Given this list of marker genes BAZ2A, GMFG, VPS54, NEMF, PRR14, KCTD12, PKP3, SEC63, GRAMD2B, LIPA, CMAS, UTP25, SLA2 (NCBI Gene Id 84174), SCAMP3, SCML4, GMFB, SEC23B, UBAC2, DPH5, DOCK2, INPP1, RPS6KB2, UBE2H, LAMTOR3, HECTD3, SNX10, SLC2A4RG, HELZ2, EVI2B, CD164, IRAK3 (NCBI Gene Id 11213), UNC5A, IRF2, EMG1, FAM53A, SSBP4, RUNDC1, PHAF1, ALKBH1, TWF2, TMOD3, JAK3, TRAPPC8, TRAM1, GIMAP4, EGR1, GRB2, ESYT1, LMBRD1, FERRY3, DBNL, TSR1, TAB2, SMAD7, MFNG, PCMTD2, AKAP8, METRNL, MTERF3, CXXC1, DPP4, CFAP141, RER1, ZYG11B, ITGA6, DUSP11, SLC15A4, PREB, SELL, RBFA, SLC35G1, USP12, RCN1, TAF8, IFT57, ACP5, PRKD3, EIF2AK1, NCLN, UBE2F, CLK4, DGKA, AGER, NDUFAF4, POU2AF1, NFKBIE, HBP1 (HMG-box transcription factor 1), ADGRA3, NFRKB, FEZ2, C14orf119, RIMOC1, SNX14, C18orf32, RAB19, SQOR, PON2, KLHDC3, RFK, CIB1, RC3H1, RHOBTB2, WDR43, MTLN, PFN1, PAPOLG, STING1, MCTP2, ATF7IP, RNASET2, OSTM1, TYROBP (transmembrane immune signaling adaptor TYROBP), ZNF260, UPF2, CISD1, ACADL, ATP10A, BCCIP, TMEM126A, YWHAZ, SLC9A9, ITGB3, TASP1, SLC25A33, RPS6KA1, PTPRE, PLCG2, GIMAP8, NARF, TENT4B, L1CAM, GDI1, ATP6V0A2, STIM2, CALCRL, SLC36A1, RSRC2 (NCBI Gene Id 65117), PHLPP1, PLOD1, BACH1, EHD3 (EH domain containing 3), UBALD2, AKIRIN1, ARHGAP1, PLCXD2, IL18RAP, SAMHD1, EEIG1, ITGB1BP1, DCAF11, SNRK, CREB3, SLAMF6, ANKRD11, RAB5IF, S1PR4, UQCRHL, ZFC3H1, LBH, PRR14L (NCBI Gene Id 84194), NDUFA6, ABCF2, PRKAR2A, C5orf34, SEC16A, ANKIB1, ENSA, HSD17B4 (NCBI Gene Id 3295), MYO6, PATZ1, RBM33, DMTF1, SEPTIN9, RBX1, SNAP23, TRPM4, MARCHF2, PNN, SRSF6, SYS1, SH2D1A, DCAF8, CYB5A, SIRT2, SIDT2, YTHDC1, CNP, ZDHHC3 (zinc finger DHHC-type palmitoyltransferase 3), SLCO4A1, SENP7, STX16, GBP7, GDAP2, SLA, SELENOO, FAM32A, BBLN, GATD3, ITPKB, SNX33 (NCBI Gene Id 257364), here is a description of the gene set: from publication Dik WA, Pike-Overzet K, Weerkamp F, de Ridder D, de Haas EF, Baert MR, van der Spek P, Koster EE, Reinders MJ, van Dongen JJ, Langerak AW, Staal FJ (PMID 15928199) studied in species Homo sapiens T cells develop from progenitors that migrate from the bone marrow into the thymus. Thymocytes are subdivided roughly as being double negative (DN), double positive (DP), or single positive (SP), based on the expression of the CD4 and CD8 coreceptors. The DN stage is heterogeneous and can be subdivided into four distinct subsets in mice based on the expression of CD44 and CD25. In human, three distinct DN stages can be recognized: a CD34+CD38−CD1a− stage that represents the most immature thymic subset and the consecutive CD34+CD38+CD1a− and CD34+CD38+CD1a+ stages. Human DN thymocytes mature via an immature single positive (ISP CD4+) and a DP stage into CD4+ or CD8+ SP T cells that express functional T cell receptors (TCR) and that exit the thymus. In this study, gene expression was measured in each of these nine stages. Human Gene Set: GSE22601_CD4_SINGLE_POSITIVE_VS_CD8_SINGLE_POSITIVE_THYMOCYTE_DN Genes down-regulated in single positive thymocytes: CD4 versus CD8.